The following is a description of a gene set: from publication Zak DE, Andersen-Nissen E, Peterson ER, Sato A, Hamilton MK, Borgerding J, Krishnamurty AT, Chang JT, Adams DJ, Hensley TR, Salter AI, Morgan CA, Duerr AC, De Rosa SC, Aderem A, McElrath MJ (PMID 23151505) To better understand how innate immune responses to vaccination can lead to lasting protective immunity, we used a systems approach to define immune signatures in humans over 1 wk following MRKAd5/HIV vaccination that predicted subsequent HIV-specific T-cell responses. Within 24 h, striking increases in peripheral blood mononuclear cell gene expression associated with inflammation, IFN response, and myeloid cell trafficking occurred, and lymphocyte-specific transcripts decreased. These alterations were corroborated by marked serum inflammatory cytokine elevations and egress of circulating lymphocytes. Responses of vaccinees with preexisting adenovirus serotype 5 (Ad5) neutralizing antibodies were strongly attenuated, suggesting that enhanced HIV acquisition in Ad5-seropositive subgroups in the Step Study may relate to the lack of appropriate innate activation rather than to increased systemic immune activation. Importantly, patterns of chemoattractant cytokine responses at 24 h and alterations in 209 peripheral blood mononuclear cell transcripts at 72 h were predictive of subsequent induction and magnitude of HIV-specific CD8(+) T-cell responses. This systems approach provides a framework to compare innate responses induced by vectors, as shown here by contrasting the more rapid, robust response to MRKAd5/HIV with that to yellow fever vaccine. When applied iteratively, the findings may permit selection of HIV vaccine candidates eliciting innate immune response profiles more likely to drive HIV protective immunity. Genes up-regulated in peripheral blood mononuclear cell 3d vs 0d in adults (20-50) after exposure to MRKAd5 HIV-1 gag/pol/nef, time point 3D. Comment: Table includes specific cell types Human Gene Set: ZAK_PBMC_MRKAD5_HIV_1_GAG_POL_NEF_AGE_20_50YO_3DY_UP species: Homo sapiens, and this is the list of marker genes: HSPA6 (NCBI Gene Id 3310), PML, LGALS9B, FFAR2, SIGLEC7, MOV10, TDRD7, IFI44L, CX3CR1, GRN, SAMD9, ANKFY1, TFEC, CARD6 (caspase recruitment domain family member 6), GPBAR1, WSB1, MS4A4A, PLSCR1, CALML4, IRF9, GCH1, OASL, SCARB2, TAP1, TNFSF10, HERC5, TCF7L2 (transcription factor 7 like 2), TRIM22, MAFB, SAMD9L, EPSTI1, IFITM1, NLRC4, WARS1, OAS3, CASP5, H1-0, CYSLTR1, ABI3, TOR1B, GBP1, LAP3, TRIM21, JUP, SERPING1, CCR1, ZNFX1, TLR6, PARP12, AIM2, FGD2, CMPK2, TLR2, KMO, DDX60, SHISA5 (shisa family member 5), MTSS1, KCNJ2, STAT1, TASL, IGSF6, RSAD2, DHX58, LY6E (NCBI Gene Id 7999), IFI44, IFI16, IFI6 (NCBI Gene Id 2537), LGALS3BP, CSF1R, LRRC25, MBOAT1, FPR2, CXCL10, LST1, FLVCR2, SP110, OAS1, USP18, CASP10, MERTK, HSH2D, XAF1, DUSP6, ACP2 (NCBI Gene Id 96117), FPGT, GIMAP8, CLEC7A, FGD6, SLC38A9, SLC20A1, IFIT3, C3AR1, TLR1, HERC6, RIGI, MX1, FCGR3A, MX2, NMI, ZBP1, CTSL, IFI27, IL1RN, SUOX, IFIT1, LGALS9, P2RX7, SECTM1, SQLE, MARCKS, FPR3, CMTR1, TRIM38, IFIT2, UBE2L6, TRIM5, TNFSF13B, IFITM3, SIDT2, CMKLR1, SIGLEC1, IFIH1, PARP9, EIF2AK2, MYOF, HAVCR2, C1QB, CD101, ALPK1, CD300E, OAS2